The following is a description of a gene set: Human Gene Set: GOBP_REGULATION_OF_PEPTIDE_TRANSPORT studied in species Homo sapiens Any process that modulates the frequency, rate or extent of the directed movement of peptides, compounds of two or more amino acids where the alpha carboxyl group of one is bound to the alpha amino group of another, into, out of or within a cell, or between cells, by means of some agent such as a transporter or pore., and this is the list of marker genes: PIM3, NR1D1, TM7SF3, SYT7 (synaptotagmin 7), PTPN11, ANO1, CHD7, CELA2A, HFE, PASK, SLC25A22, NPFF, INHBB, AACS, TNFSF11, CRH, FFAR4, OSBP, RBP4, BAD (NCBI Gene Id 572), FGG, NKX6-1, REST, JAGN1, GABBR1, SCT, GIP, CAPN10, PRKD1, PLA2G6, CRHBP, BLK, EPHA5, F2, ADORA1, GHRL, ADCYAP1, CARTPT, FOXO1, FFAR3, DRD2, GIPR, HIF1A, NLGN2, BMAL1, NNAT, CD74, HLA-DRB1 (NCBI Gene Id 730415), DOC2B, RFX3 (NCBI Gene Id 5991), UCP2, AIMP1, GLUD1 (NCBI Gene Id 2746), TCIRG1, CDK16, F2RL1, APLN, SYTL4, UCN, ITSN1 (intersectin 1), PRKAR1A, ILDR1, PER2, NDUFAF2, PRKN, MLXIPL, IL6, PDE8B, GNAS, F2RL2, SELENOT, SOX4, GHRHR, BMP8A, GNAZ, SIRT3, STXBP4, MPC2, MYRIP, GHRH, GPRC6A (NCBI Gene Id 222545), SERP1, FFAR2, SLC16A1, NPY2R, JAK2, MTNR1B, IFNG, PICK1, ADRA2A, IRS1, RAC1, G6PC2, SIRT6, RAPGEF3, RPH3AL (rabphilin 3A like (without C2 domains)), GPLD1, CCL5, FGB, S100A8, ZBED6, TNF, ORAI1, ADCY5, PFKL, ADRA2C, BAIAP3, SLC9B2, ITPR1, PPARD (peroxisome proliferator activated receptor delta), TRH, INS, SRI, GNAI1, FFAR1, SLC8B1, PCK2, GRP, FKBP1B, NR0B2, SLC26A6, CCN3, GNA11, CFTR, ENY2, ABCC8, PSMD9, PFKM, MIDN, LRRC8A, KLF7, TCF7L2, EFNA5, CASR, PHPT1, NOS2, FGA, EIPR1, SNAP25 (NCBI Gene Id 6616), BRSK2, NMU, RAB8B, GCK, SREBF1, GCG (NCBI Gene Id 2641), KCNJ11, GPER1, ACSL4, NEUROD1, TRPA1, PRKCA, IL1B, ADCY8, RAPGEF4 (Rap guanine nucleotide exchange factor 4, NCBI Gene Id 11069), SIRT4, TUNAR, RASL10B, KCNK16, RFX6, NR1H4, PDX1, VSNL1, ACVR1C, TFR2, IRS2, GNAO1, PAX8, HTR2C, SSTR5, PRKCB, STX1A, DYNLL1, ABAT, HNF4A, TFAP2B, HMGA2, SYBU, ECRG4, SLC30A8, C2CD2L, PLCB1, NADK, SLC2A2, CA2, CHGA, PFKFB2, SIDT2, CLOCK, TRPM5, GPR68, GPR27, FAM3D, UQCC2, CHRM3, PRKCE, HADH, LRP5, OXCT1, C1QTNF12, ISL1, GHSR, CPT1A, UCN3, PRKACA, LEP, MCU, STX4, TARDBP, ALOX5, ENSA, TRPM4, PPP3CB, ABCA12, FOXA2, KCNA5, CD38, KCNB1